The following is a description of a gene set: studied in species Homo sapiens Understanding the response of memory CD8 T cells to persistent antigen re-stimulation and the role of CD4 T cell help is critical to the design of successful vaccines for chronic diseases. However, studies comparing the protective abilities and qualities of memory and naïve cells have been mostly performed in acute infections, and little is known about their roles during chronic infections. Herein, we show that memory cells dominate over naïve cells and are protective when present in large enough numbers to quickly reduce infection. In contrast, when infection is not rapidly reduced, memory cells are quickly lost, unlike naïve cells. This loss of memory cells is due to (i) an early block in cell proliferation, (ii) selective regulation by the inhibitory receptor 2B4, and (iii) increased reliance on CD4 T cell help. These findings have important implications towards the design of T cell vaccines against chronic infections and tumors. Genes down-regulated in comparison of splenic primary CD8 effector T cells at day 8 post-acute infection versus splenic secondary CD8 effector T cells at day 8 post-acute infection. from publication West EE, Youngblood B, Tan WG, Jin HT, Araki K, Alexe G, Konieczny BT, Calpe S, Freeman GJ, Terhorst C, Haining WN, Ahmed R (PMID 21856186) Human Gene Set: GSE30962_PRIMARY_VS_SECONDARY_ACUTE_LCMV_INF_CD8_TCELL_DN, and this is the list of marker genes: METRNL, NDRG3, SFXN3, WLS, LINC01160, HLA-E, CDK13, ADGRG5, CSN2, HMGA2, CHST11, PRRC2B, CRYGS, CCDC158, KLHL24, ADRB1, RSRP1 (NCBI Gene Id 57040), TKTL1, DCAF11, FBXO27, F7, KDM7A, RBM33, ZUP1, ARHGEF12, DENND2A, EPHA1, KIF13B (kinesin family member 13B), SELENOP, PRRX2, IL17D, SAT1, GNRHR, PAQR7, GGH, FGF13, PVT1, TMEM38B, MYLIP, PAX3, C10orf120, TTC39C, PRUNE1, FAM78B, ITPRIPL2, SORCS3-AS1, FCGR2B, RORA, SYN3, PLEKHM3, RPL37A, SOWAHB, PTPRJ, DGKI, S100PBP, CCL5, CALCB, ZKSCAN3, SNTB1, CAMK2N1, FRAT2, COQ8A, IL15RA, ZDHHC2, KDM4C, NOD1, ZXDC, FHL5, HLA-B, MAPRE2, TRIM36, DNAJB2, CNRIP1, RGS2, ENPP1, C4BPA, HMX1, MAJIN (NCBI Gene Id 283129), STPG1, RNF111, ARHGAP25, MOG, TRIM42, SHISA3, PCMTD1, YES1, CUTC, ARL13B (ADP ribosylation factor like GTPase 13B), SDK1, DYRK3, ZNHIT6, ZNF385A, FMO3, HSFY2, AGTR1, NLRX1, PRRG4, PROS1, PDXK, PNPLA7, RCN1, UBASH3B, SS18L1, SERTAD3, EPS8, CORO2A, SPMIP3, ABO, DAAM1, RAP2A, CACUL1, FBXO43, MAGEE1, CDC14B, AKT3, NPC2, KIFAP3, TMEM63A, RCAN1 (regulator of calcineurin 1), H2BC18, TXNIP, NT5E, RBL2, IL15, HIF1AN, ZCCHC24, CREBRF, TRIM65, CDADC1, HERC3, GIMAP1, ADI1, RARRES1, TMPRSS13, VWA5A, CYRIA, CP, GSTM3, NSUN6, PANK3, SLC28A2, CARD6, PGP, MYOM2, MAT2B, AQP3, PHF13, RNF181, LANCL1, MACROD1, TMEM151A, NCAN, PEX26, SERPINB1, RNF128, PDZRN3, VOPP1, RAI14, PCMTD2, DNAJB4, SNX5, DYNC1H1, TMEM59, SHPK, CPEB3, SYNE1, HSD11B2, SUOX, STAP1, RBM47, KLHL42, DSTN (NCBI Gene Id 11034), NR1D2, TMT1A, MTERF1, PRR13, LYPD6B, LDLRAP1, AQP9, PRR14L, PPIL3, KLRK1, BMPR1A, GOLM1, PPM1L, PCTP, DICER1, PAWR, KCNJ8, ARL4A, TNFSF14, SERINC1, SERPINB11, PIP4P2, ACSS1, B3GALNT2, PIM1, PEA15, KIF5C, ZSCAN26